Given this list of marker genes ZMYM4, ENO2, ARIH1, BRIX1, GMPPB, PLEC, NAA80, RELA, LAMA4, ABCC2, FTH1, STX12 (syntaxin 12), PPP4R2, SLC7A11, KCTD10, ELANE, PTGER4, ATP1A1, HAPSTR1, PTTG1IP, ATP1B3, TGM2, ID2, EXOSC8, CACUL1, TRNT1, ABCC1, POU3F1, IL1R1, RAP1B, CHP1, LPIN2, PHLDB1, GATA4, DNAL4, ARF4, ARPC3, CMTR1, DTD2, MKRN2, TNFRSF1B, RBX1, CNDP2, KRT31, BCL2L11, STAT4, CCDC6 (NCBI Gene Id 8030), AASS, TES, RPL7A, GJA1, RPL41, PTPRN2, MAP4K4, BLK, MAP3K1, CHRNA6, OAT, MC1R, NDEL1, ZWINT, GLA, FASTK, SERPINE2, GOSR2, DDX6, GTF2E2, CD74, DHH, BHLHE40, SRA1, LAMTOR3, BMP8B, GABARAPL1, WSB2 (WD repeat and SOCS box containing 2), SORBS1, SPCS1, SAMD4B, FYN, CTNNBIP1, ACOT9, CYP21A1P, LITAF, EBF2, IFRD1, ATP6V1D, AHR, HLA-DRB1, GCM2, SRGN, GPSM1, MAT2A (methionine adenosyltransferase 2A), NFKB2, TNFRSF11A, IL7R, TSC1, CLDN7, RO60, CDX4, PELO, JUP, DHRS3, TRPC4, CH25H, COPRS, ANXA5, ZFX, RAB8B, IL1RN, RPL34, TRIM25, JARID2, SOCS5, CTSK, ACTB, EHD1, SLC5A1, MIF4GD, CORO1C, RNF19A, NOG, KIAA1217, TDRP, KRT33B, UTP4, KARS1, CST9L, PSMD11, SLC31A1, FAU, CCAR1, IFNA1, NUDT9, ARID3B, PSMC1, COQ10A, BMAL1, IDI1, PDCL3, HSPA9, AGO2, OSMR, PPP2R2A, TUBB6, SUDS3, LHX8, EPB41, CRY1, APIP, ATP5MF, GRB7, USP14, LRRC59, POLB, SRXN1, SCIN, NF2, M6PR, TMEM30B, SFN, LCP1, NDUFA1, RAG1, CD9, SERPINE1, SETD1A, GNA13, CDKN1A, FKBP1A, COL19A1, FBXL3, ZFAND2A, MRTFA, EZR, IGSF8, AP1G1, CDC5L, GPX1, HOMER3, SYT2, COPB1, CCNL2, TRPC5, FBRS, PFDN5, MXI1, STAT5A, HSP90AB1, HLA-C, CNOT1, CDIP1, B3GALT1, PRDX6, IL15, WDR26 (WD repeat domain 26), RNF4, DYRK1B, HSPD1, CSNK2A2, NPTX2, here is a description of the gene set: Human Gene Set: GSE339_EX_VIVO_VS_IN_CULTURE_CD4CD8DN_DC_DN Genes down-regulated in comparison of ex vivo CD4- CD8- dendritic cells (DC) versus cultured CD4- CD8- DCs. species: Homo sapiens from publication Edwards AD, Chaussabel D, Tomlinson S, Schulz O, Sher A, Reis e Sousa C (PMID 12816982) The functional relationships and properties of different sub-types of dendritic cells (DC) remain largely undefined. We used a global gene profiling approach to determine gene expression patterns among murine splenic CD11c high DC subsets in an effort to better characterise these cells.